The following is a description of a gene set: studied in species Homo sapiens Human Gene Set: ELF1_Q6 Genes having at least one occurrence of the motif RNWMBAGGAART in the regions spanning 4 kb centered on their transcription starting sites. This matches the ELF1 transcription factor binding site V$ELF1_Q6 (v7.4 TRANSFAC)., and this is the list of marker genes: SHC3, CD274, RASIP1, PFKFB4, DPP8, GPR31, TEK, TLN1, ELF4, MRGPRG-AS1, AIF1, PKN1, MSH5, BAZ1A, IPCEF1, DPP3 (NCBI Gene Id 10072), PRKRIP1, BAHD1, MYL1, PABPC1, CAPN3, DUSP22, IQGAP1, SIX4, RELA, SORL1, NCK1, FCRLA, TBC1D17, SEL1L3, RPL34-DT, FGF20, RUFY1, TXK, GPX1, PATZ1, NCKAP1L, PIK3CD, SPRED2, RETREG2, PITPNM1, ZNF646, DNAJA2, TNFSF13, FFAR4, MTPN, TACR1, FCRL1, MITF, PTPRH, SLC39A13, ADAP1, SLC9A9, TAOK2, COL6A3, ENTR1, ADD3, FZD10, ELOVL1, CDH5, STX5, CCL23, CARD9, VSIG10, ARL6IP5, LRRFIP1, ECHDC2, PPP3CA, PRDM5, WIPI2, E2F3, TIE1, GNGT2, FBXW4, ARPC2, FAM3D, ACSL4, LAG3, FAM110A, ORMDL3, ARRB2, KCNAB1, MAP3K11, PSPN, RAC1, FGD2, NRP1, MARCKS (NCBI Gene Id 4082), RPL34, CTCF, ABI3, ERF, GRB2, SAMSN1, KIF3C, RLIM, RPL17, DERL1, CALCRL, VIM, IL7R, LAMA3, AKT1S1, GDPD5, CAMK1D, PUM1, REL, MED15, UBE2Q2P1, HOXB4, TRAPPC12, SAT1, HOXC4, CDC14A, BRINP3 (NCBI Gene Id 339479), CTSA, HOXC10 (NCBI Gene Id 3226), SF1, STAT6, SCIMP, GMIP, STAB1, CREB3, ATP2A3 (NCBI Gene Id 489), MYO1C, PAX6, CSF1, PLEKHH2, TNIP3, DGKZ, MIDEAS, ITGB7, KLF12, XPR1, CNOT6L, IKBKB, FCER1G, TLR4, CRACR2B, AGPAT1, APOBR, EIPR1, FBLN5, INPP5F, TMEM88, IRF8, TMPRSS11D, BTBD16, ASPHD1, PI4K2A, RCL1, CHMP1B, DCAF1, TRAF3IP3, ZNF687, NR2C2, OSER1, GAL3ST3, FUT11, EIF4EBP1, WAS, ACSL5, CCDC88B, LIMD2, SUPT16H, P2RY10, C1orf43, PCDH9, CTNND1, TFE3, MICAL2, TM6SF1, NEURL2, CEBPE, DAPP1, MAP4K2, NCAM1, IKZF2, TFAP2C, XIAP, CLIC1, NTS, HM13, LIMS1, RASGRP3, RNF5, CDKN2A, FOXO4, ELMO1, TMEM154, VAV1, MR1, SLC9B2, STIM1, TYROBP, S1PR4, RAB25 (NCBI Gene Id 57111), NASP, ARHGDIB, RNF31, RALA, ANKRD28, BRAF (B-Raf proto-oncogene, serine/threonine kinase), DMTF1, KLF13, PI16, CD37, NEDD4, NIPAL3, MPPED2, CAMK2B, IKZF3, CNPPD1, TGFB1, CD79B, JARID2, IL2, C1QA, ALOX5AP, PPP4R3B, PLCB2, KCNMB3, SRSF8, TWIST1, SNX2, ESM1, GAREM1, ITPR2, LRRC8A, MLLT3, TBC1D8, CLEC12A, MYADM, CREBBP, MADD, STX19, ZNF668, BEND6 (NCBI Gene Id 221336), CMAS, PSME2, FAM241A, NFIA, TMEM178A, RBFOX1, MRPL24, NUFIP2, RAB39A, TBC1D10B (NCBI Gene Id 26000), GOLPH3L